The following is a description of a gene set: Human Gene Set: GGATTA_PITX2_Q2 Comprehensive identification of all functional elements encoded in the human genome is a fundamental need in biomedical research. Here, we present a comparative analysis of the human, mouse, rat and dog genomes to create a systematic catalogue of common regulatory motifs in promoters and 3' untranslated regions (3' UTRs). The promoter analysis yields 174 candidate motifs, including most previously known transcription-factor binding sites and 105 new motifs. The 3'-UTR analysis yields 106 motifs likely to be involved in post-transcriptional regulation. Nearly one-half are associated with microRNAs (miRNAs), leading to the discovery of many new miRNA genes and their likely target genes. Our results suggest that previous estimates of the number of human miRNA genes were low, and that miRNAs regulate at least 20% of human genes. The overall results provide a systematic view of gene regulation in the human, which will be refined as additional mammalian genomes become available. studied in species Homo sapiens Genes having at least one occurrence of the highly conserved motif M93 GGATTA in the regions spanning 4 kb centered on their transcription starting sites. This matches the PITX2 transcription factor binding site V$PITX2_Q2 (v7.4 TRANSFAC). from publication Xie X, Lu J, Kulbokas EJ, Golub TR, Mootha V, Lindblad-Toh K, Lander ES, Kellis M (PMID 15735639), and this is the list of marker genes: HOXA2, CLOCK, AP1S2, PRDM8, PRRC2A, PRKCE, HRK, CTSC, ZBTB37, ATXN1, TBR1, CXXC5, POLD4, ZMYM4, TMEM132E-DT, PSD, POU4F3, FZD4 (frizzled class receptor 4), CNOT7, PHC2, TULP1, CPLX4, SLITRK3, LTBP1, SYNGR1, RBM47, TMEM182, TRPM3, FBXO11, MIR137HG, RARB, ZEB2, PRRX1, NTN5, NACA, LUC7L, NOTCH2NLA, NCALD, BRD4, PGF, PHF23, ANXA11, CAMK2A, ACKR1, AGA, STC1, GTF2A1L, SLC6A15, PNPLA3, LRIT1, SERPINI2, TLK2, PRPF8, ARNT, RYBP, AANAT, LLGL2, TMEM108, FAM53B, LMO1, LGI1, SMG6, SCAF4, KCNQ1DN, ACVR1, SUCNR1, CD2AP, USPL1, CNGB3 (NCBI Gene Id 6021), FLRT3, RAI2, SLC22A6, SOAT2, ANKRD28, PITX2, KNL1 (NCBI Gene Id 57082), CABP5, JARID2, DNM1, GOLGB1, TAL2, ADGRL2, CREB5, BICDL1, SP7, MED13, CCDC6 (NCBI Gene Id 8030), CDKL2, PPP1R16B, MSX1, VEPH1, BEST3 (bestrophin 3), ENTPD3, RBP3, NDUFB9, PHF21A, NEBL, RP1L1, MYOG, UBAP2L, PRDM13, DCT, KRT3, CABP2, DALRD3, ZNRF2, NAV3, RPS6KA3, PMCH, DNAH7 (dynein axonemal heavy chain 7), RBPMS, ADORA1, SIM1, MAP2K6, SLC13A1, GKN1, ATP6V0A4, NDST3, BTG1, CNPY3, XK, MTCL1, CRX, TBX20, FGFR3, KRT28 (keratin 28), DHX30, DNAAF2, SLC44A1, ARX, RAB24, KCNK9, HSF2, HMGN5, UBXN4, FGB, ACP4, C8A, PBX1, EFEMP1, MAPK9, LZTS2, SHOX2, TERT, EPHA2, SYNJ1, ASB2, MYOCD, ASB11, PRELID1, SP8, NEUROD2, LINC01101, LAMC2, SLC39A12, C2CD2L, EN1, TCF7, EDN2, ITPR1, TM4SF4, ACKR3, CD40LG, TPM2, SLC5A3 (NCBI Gene Id 6526), MSS51, TDRD7 (NCBI Gene Id 23424), KLF5, SLC30A8, SYNPR, RP1, MGAT4C, RTL9, MYH6, ZFHX3, HMG20A, NUFIP2, PLA2G5, OTX2, CDC42BPA, TRIP10 (thyroid hormone receptor interactor 10), BRD3, PDE6C, KLK13, GABRA1, DMPK, ENOX1, DMD, GASK1B, ADD3, ACADVL, TRPS1, LMOD3, SEMA3A, SCN3A, IRX3, POFUT1, LMO3, PROK2, LINC00310, SEMA6A, HOXB8, IRX5, NPPC, PPFIBP1, ITSN1, IFNG, NSF, FOXO4, MYO1B, ABHD11, SLC4A5, NR3C2, TMEM35A, IQSEC1, KCNH5, ANKRD29, TEX11, PRDM10, KCTD15, DUSP5, CCDC80, ANKMY2, SLC4A7, CRK, CLTRN, VAX1, MYL6B, PAX2, MITF, SLITRK2, SLC25A14, KCNH6, TIGD2, TNS1, KLK12, RPL17 (NCBI Gene Id 6139), MYB, INSM1, BFSP1, NR2E1, PCBP4, TMEM88, GPHB5, CACNA2D4 (calcium voltage-gated channel auxiliary subunit alpha2delta 4), SOCS2, USP13, SP6, SLC35A2, GPBP1, H1-0, NOVA1, MECP2, KAZALD1, TENM1, BCL2, TLE4, NOTCH2, HMGB1, LIX1, GNB3, PROC, MID1, ESRRA, UBTF, PNOC, PDE4B, AHCYL2, TTC9C, PPM1B, ISL1, TNNI1, ACAA2, ZNF385A, GK, RLBP1, ZNF503, PIAS3, EYA1, SOX14, NPEPPS, CIZ1, TMEM100, FIBCD1, CBX2, SIPA1L1, AMER1, MEOX2, SKIDA1, NRIP3, ANGPTL2, CRYGS, ADNP, BZW2, UTRN, ARHGAP26, DDX17, TOB2, EMILIN3, GRID2, PLCD4, ADAM9, GNB2, SUPT16H, NDUFV1, MTRFR, MPP4, WNT3A, SRR (serine racemase), CSMD3, CREB3, PHC1, SPRY2, CDKL5, ZNF281, SLC12A1, PRX, SUFU, DDX25, CNBP, NPVF, RHO, SYTL2, CHRNE, PBXIP1, ADAMTSL1, FOSL2, ATP6V1B2, MYPN, HPCAL4, TLN1, NEUROD4, KCNJ1, RAB3IP (RAB3A interacting protein), RORC, RNF43, STAT5B, SLMAP, H4C3, SAMD7, ASCL4, RRAS, MRPS18B, GAD1, SH3RF1, KITLG, SRPX2, RTN4RL1, PROSER3, PLA2R1, BRCA2, PHOX2B, ARAP3, BRWD3, NT5C, SLC30A1 (NCBI Gene Id 7779), KRT24, PPP3CA, CAMK1G, HOXD3, UBAP1 (ubiquitin associated protein 1), IKZF2, PCSK1 (proprotein convertase subtilisin/kexin type 1), TMEM135, OCLN, GPR158, MYBPC1, RXRG, PLEKHA6, USP54, MCTP2, IMPDH1, PAX7, FOXF2, KTN1, TRIB1, FEZF2, BBS5, ELMO1, SLC26A9, SLC13A4, TSPAN31, ORC4, TCF21, PAQR4, PART1, C12orf50, GLRA1, CPNE1, LIN28A, BRINP3, PLAGL2, TATDN1, ABL1, POU2F1, NANOG, SPDEF, TADA1, KLK9, PCYT1B, CABP4, PDE1A, CLCA3P, MAP3K5, IRX6, PRICKLE2 (prickle planar cell polarity protein 2), PITPNM1, ROBO3, IL1RAPL1, STRA6, MFRP, NUP54, SNCAIP, TMEM132E, LINC00052, MAP2K5, NKX6-1, OTULIN, CNTFR, TM2D2, ZBTB18, SLC4A2 (solute carrier family 4 member 2), MBD6, ARMCX3, SPAG16, EVA1A, NTRK2, NYX, HYPK, MLLT6, CNGB1, DCX, TENM3-AS1, PTPN4, JMJD1C, ATP13A4, BAIAP2L1, SLC6A4, LRTM1, SREK1, CYP2F1, GUCY2F, GLI2, ASPA, ITGA3, DLG4, LINC00314, DUSP10, LMX1A, RBMS2, EFS, HSPB6, TYRP1, RUNX1T1, LRRC8D, MAML3, ACTR1A, KRT76, FUT11, RGR, CHST1, CBX4, JAKMIP2, PRDM12, GADD45B, SRGAP2, CLSTN3, ZFP36L1, USP4, JUND (NCBI Gene Id 3727), SLC16A8, TRIM55, FOXA1, ADAMTS4, IFT46, AMIGO2, SOX15, TCEAL7, DHRS3, MAP2, LMTK2, RFLNB, PSMB3, C1orf87, HIC2, APRG1, RFX4, KLHL41, MTSS1, CGGBP1, SPMIP8, PDGFC, NOG, EGFLAM, MYF6, EPB41L5, SULF1, PATL1, SLC39A2, HOXB6, RNF220, DHX58, GPM6B (NCBI Gene Id 2824), ROBO1, FIGN, RTN3, DUSP3, CACNA1S (NCBI Gene Id 779), MBNL2, NDUFV1-DT, DUSP6, SP4, SLITRK5, LIMA1, CYSLTR1, ABHD17B, SLC5A2, JOSD1, DDR2, ACTR10, SMARCA2, TGIF1, CPEB4, MPPED2, PDXK, ANO1, NLK, FBXO36, ZNF516-DT, NIPBL, PLPP2, ARFIP1, C16orf74, SLC12A5, GJD2, ESM1, LINC03040, COL2A1, KHSRP, RMDN2, CLEC18C, IP6K2 (NCBI Gene Id 51447), C6orf62, PPP3R1, ARF6, LRP2, SIX1, TCF4, TRIML1, CREM, RBM26, LIFR, MOB4, MS4A1 (membrane spanning 4-domains A1), C7 (NCBI Gene Id 636878), CREBRF, CASQ2, EHF, GRM6, PABIR1, IGSF3, JOSD2, OTOP3, HOXB4 (NCBI Gene Id 3214), NDUFS2, IGF2BP3, ABCA4, HNRNPD, SOX9, NDUFAF3, PPP1R10, HOXA11, CTNNA3, SEC14L3, MYRF, MIP, ZNRF1, MLLT3, VEZF1, ARHGEF15, SKIL, CTBP2, ACVRL1, MFGE8, MAB21L1, RORA, IFT43, HR, UNC13B, DLL4, SRRM4, LINC00652 (long intergenic non-protein coding RNA 652), RAX, FOXP3, MCHR1